Given this list of marker genes CCDC198, TBXT (T-box transcription factor T), INF2, PTPN3, PDLIM7, TBC1D30, ADAMTS2, PRELID3A, KHK, RAB20, MCOLN1, PLIN1, ACACA, SLC35E2A, LHB, PTCD3, FAM182A, KLK1, DCAF1, MCM7, SLC19A1, AKR7A2, CBLIF, SLC26A6, TRAC, ZNF136, LRFN4, CBX2, TPPP3, PLS1, NAV2, SNCAIP, DIRAS2, ACTN3, SETD5, OR7C2, DOT1L, LCT, FBXO2, CTRC, ACAD8, APOM, ZNF443, EPHA1, SLTM, ZKSCAN7, HCFC1R1, HMGN5, DDX49, MED12, DGCR5, IFNA4 (interferon alpha 4), PIEZO1, VWA7, EPHA2, ZNF143, BDH1 (NCBI Gene Id 622), SLC16A6, MRC2, ETV5, SIK2, MED4, ATP4B, WWC3, MID2, MMP20, OMG, SGCB, ZNF223, CDK17, ZNF45, NOP14 (NOP14 nucleolar protein), CRYGC, SLC35F6, CEBPA-DT, TXNRD3, RASIP1, HKDC1, AQP8, LILRB5, SLC2A2, GPX3 (NCBI Gene Id 2878), CCN5, METTL22, SCN2B, YBX2, NFKBIB, PTDSS2, PLOD1 (NCBI Gene Id 5351), IL17B, PRDM11, TRIM49, CYP1A1, AQP1, RGSL1, MYH15, P2RX1, TF, ODAM, MAP3K9, ADTRP, L1CAM, CDR2L, FERMT1, RRH, ITPKC, DHX8, AOC2, DCSTAMP, HOXB7, TBK1, ZNF358, ABCA2, GIMAP6, SLC5A12, SLC8A2, DPP4, CDCA4, MIER2, ZNF76, KLK2, C8orf17 (chromosome 8 putative open reading frame 17), DHX9, PLD3, KRTAP2-4, LCN2, HSPB7 (heat shock protein family B (small) member 7), GGNBP2, GIPC1, IGSF3, PRSS22, CPLANE2, FOXJ2, ADAM18, NUPR1, NR1H2, CCZ1, MADD, SH3GL3, ZNF512B, AGRN, EPB41L4B (NCBI Gene Id 87974), SOCS7, HDAC3, TUBB1, NEUROG2, HNF4G, PBK, CACFD1, C8B, KCTD15, NFATC4, GNA11, TMSB15A, SLC22A18, FRAS1, LRPAP1, TXNL4B, USP3, ECEL1, KIT, ZSCAN32, PEX3, JAG1, TNP2, TSGA10, LARP6, JPH3, FUT6, FAM131A, RNF126P1, ARAP3, INTS15, AKAP11, PAH, TFCP2L1, GSTCD, SMG6, THBD, FZD5, PLA2G2A, IFT122, SEMG1, ATG16L1, SUGP1, LHCGR, CALML5, CAMK1G, OR7A17, ACY1, KIAA1614, CPN2, LGR5, BICC1, EIF2B5 (NCBI Gene Id 8893), KLHL2, OPCML, CHAT, TMPRSS4, here is a description of the gene set: Human Gene Set: GSE29618_PRE_VS_DAY7_POST_TIV_FLU_VACCINE_PDC_UP Systems vaccinology has emerged as an interdisciplinary field that combines systems wide measurements and network and predictive modeling applied to vaccinology. Here we used the systems vaccinology approach to study the molecular mechanisms underlying th Genes up-regulated in comparison of plasmacytoid dendritic cells (pDC) from TIV influenza vaccinee pre-vaccination versus those at day 7 post-vaccination. studied in species Homo sapiens from publication Nakaya HI, Wrammert J, Lee EK, Racioppi L, Marie-Kunze S, Haining WN, Means AR, Kasturi SP, Khan N, Li GM, McCausland M, Kanchan V, Kokko KE, Li S, Elbein R, Mehta AK, Aderem A, Subbarao K, Ahmed R, Pulendran B (PMID 21743478)